Given this list of marker genes AZU1, NUDT3, TCN1, CALU, FLOT2, GYG1, CHPF2, CAPG, MYDGF, GGH, IGHV3-72, RAB27A, RNASE3, EVA1B, S100P, MANSC1, SEL1L3, RTN3, CA1, DNAJC4, IGHG1, ARG1, S100A9, HK3, PLXND1, CC2D1A, ADAM28, LCN2, ORM1, COPE, NDST1, ENTPD1 (ectonucleoside triphosphate diphosphohydrolase 1), BPI, SERPINB10, TRABD, PGLYRP1, DHRS7, ERO1A (NCBI Gene Id 30001), GBA1 (glucosylceramidase beta 1), NPC1, TMUB2, CEACAM1, TSPAN2, CRISP3, CTSD, TM9SF1, EREG, CD24P2, IMPA2, MZB1, ABHD5, MGAM, FUT7 (fucosyltransferase 7), PRRG4, SSR1, TACSTD2, GALNS, STX3, ARF3, GPAA1, BSCL2, AGFG1, LTB4R, PDLIM7 (PDZ and LIM domain 7), CLEC5A, MMP8, CXCL2, ZNF225, CYP27A1, CAPN3, ATP8B4, PTX3, CAMP, CDA, HCAR3, MAN2A2, PADI2, RNASE4, SLPI, TNFSF13, ALOX5, NAALADL1 (NCBI Gene Id 10004), CAMKK2, ANG, CR1, CHIT1, MMP9, PGD, SRRM2, PGAP6, FLOT1, IGLL3P, CCPG1, CLMN, OLR1, CD177, MYO1F, TMCO3, SDF4, IL1R1, ADAM8, ABHD2, GSN, APMAP, CHI3L1, CYP4F3, CSF3R, PCNX1, PDIA5, ITGAM, FUT4, BST1 (bone marrow stromal cell antigen 1), ZFPL1, IGLV3-10, CDC37, YIPF3, RNF19B, TWSG1, IMPDH1, TPD52L2 (TPD52 like 2), CEACAM6, RETN, IL1R2, NEU1, IGF2R, MYO5A, TMBIM6, RAB13, JAG1, CKAP4, HP, CD163, FKBP5, ELANE, CD24P4, ASL, CD24, LTF, STAB1, RNASE2CP (NCBI Gene Id 650648), GSR, CYP1B1, PADI4, STBD1, HOMER3, MAPK14, PCOLCE2, APLP2, PBX2, CEACAM8, SLC26A6, PYGL, P4HB, PLBD1, UGCG, NCF4, ANXA3, TKFC, ZNF318, ALOX5AP, PRTN3, RGL2, SPRY2, NT5DC2, SLC2A5, F5 (coagulation factor V), DGAT1, ELOVL1, here is a description of the gene set: from publication Ramilo O, Allman W, Chung W, Mejias A, Ardura M, Glaser C, Wittkowski KM, Piqueras B, Banchereau J, Palucka AK, Chaussabel D (PMID 17105821) species: Homo sapiens Genes down-regulated in comparison of peripheral blood mononuclear cells (PBMC) from patients with acute E. coli infection versus PBMC from patients with acute S. pneumoniae infection. Each infectious agent represents a unique combination of pathogen-associated molecular patterns that interact with specific pattern-recognition receptors expressed on immune cells. Therefore, we surmised that the blood immune cells of individuals with different infections might bear discriminative transcriptional signatures. Gene expression profiles were obtained for 131 peripheral blood samples from pediatric patients with acute infections caused by influenza A virus, Gram-negative (Escherichia coli) or Gram-positive (Staphylococcus aureus and Streptococcus pneumoniae) bacteria. Thirty-five genes were identified that best discriminate patients with influenza A virus infection from patients with either E coli or S pneumoniae infection. These genes classified with 95% accuracy (35 of 37 samples) an independent set of patients with either influenza A, E coli, or S pneumoniae infection. A different signature discriminated patients with E coli versus S aureus infections with 85% accuracy (34 of 40). Furthermore, distinctive gene expression patterns were observed in patients presenting with respiratory infections of different etiologies. Thus, microarray analyses of patient peripheral blood leukocytes might assist in the differential diagnosis of infectious diseases. Human Gene Set: GSE6269_E_COLI_VS_STREP_PNEUMO_INF_PBMC_DN